The following is a description of a gene set: RANKL/RANK signaling studied in species Homo sapiens Human Gene Set: WP_RANKLRANK_SIGNALING, and this is the list of marker genes: LYN, SPI1, TRAF2, FOS, CALCR, MAPK9, RAC1, MAPK14, NFKB1, MITF, PLCG1, MTOR, CDC42, TRAF5, CTSK, CBL, TRAF6, AKT2, NFKB2 (NCBI Gene Id 4791, nuclear factor kappa B subunit 2), MAP2K1, TRAF3, PAPSS2, IKBKG, NFKBIA, NFATC1, FHL2, PIK3R2, SRC, GAB2, IKBKB, TAB1, PTK2, AKT1, PIK3R1, CHUK, RELB, SYK, MAP2K6, TNFRSF11B, TRAF1, TAB2, SQSTM1 (sequestosome 1), MAPK8, JUN, MAPK3, MAP3K7, TNFRSF11A, MAP2K7 (NCBI Gene Id 5609), ACP5, VCAM1, MAPK1, ICAM1, STAT1 (signal transducer and activator of transcription 1), RELA, TNFSF11